The following is a description of a gene set: studied in species Homo sapiens Human Gene Set: HP_MULTIPLE_EPIPHYSEAL_DYSPLASIA Multiple epiphyseal dysplasia, and this is the list of marker genes: KIF7, RNU4ATAC (NCBI Gene Id 57788), MATN3, PHYH, EIF2AK3 (eukaryotic translation initiation factor 2 alpha kinase 3), TRAPPC2, PEX7 (peroxisomal biogenesis factor 7), COL9A1, SLC26A2